Given this list of marker genes TNRC6A, TIMM9, RPS6KB1, MIR9-1HG, MCF2, SDR9C7, CHD2, ZNF532, HOXB6, BHLHE40, PRAC1, SLITRK1, MYL3, GNAZ, KCNMB2, HOXC13, KIAA0586, NFE2, DMD, ERBIN, TMEM132E, TRPS1, MT-ND1, INTS8 (integrator complex subunit 8), NPFFR2, KCNJ2, TMEM132E-DT, NFIB, ZFYVE1, SLCO1C1, NOG, ARMC8, MEF2C, EPN3, PSMC3IP (PSMC3 interacting protein), STAC2, TNKS1BP1, HOXC4, SOCS5 (NCBI Gene Id 9655), HNF1B, SEZ6L, CPNE1, DRAM2, WFIKKN2, BCL11A, NFIL3, LINC00905, HOXC6, IL2RA, MLLT6, HOXB13 (NCBI Gene Id 10481), BCL11B, FLT1, USP34, AAK1, CLUH, INSR, CTNND2, MT-ND2, EXOSC9, AMD1, GK, WBP1L, ESRP2, NOL4L, HOXC10, FGF9, CLUAP1, TUBD1, FOXO1, ITGB8, ABTB2, MALL, KLK15, RASAL1, IRAG1, GNAO1, GPR155, here is a description of the gene set: Human Gene Set: GCNF_01 Genes having at least one occurrence of the motif NTCAAGKTCAAGKTCANN in the regions spanning 4 kb centered on their transcription starting sites. This matches the NR6A1 transcription factor binding site V$GNCF_01 (v7.4 TRANSFAC). species: Homo sapiens